The following is a description of a gene set: from publication Setlur SR, Mertz KD, Hoshida Y, Demichelis F, Lupien M, Perner S, Sboner A, Pawitan Y, Andrén O, Johnson LA, Tang J, Adami HO, Calza S, Chinnaiyan AM, Rhodes D, Tomlins S, Fall K, Mucci LA, Kantoff PW, Stampfer MJ, Andersson SO, Varenhorst E, Johansson JE, Brown M, Golub TR, Rubin MA (PMID 18505969) species: Homo sapiens Human Gene Set: SETLUR_PROSTATE_CANCER_TMPRSS2_ERG_FUSION_UP BACKGROUND: The majority of prostate cancers harbor gene fusions of the 5'-untranslated region of the androgen-regulated transmembrane protease serine 2 (TMPRSS2) promoter with erythroblast transformation-specific transcription factor family members. The common fusion between TMPRESS2 and v-ets erythroblastosis virus E26 oncogene homolog (avian) (ERG) is associated with a more aggressive clinical phenotype, implying the existence of a distinct subclass of prostate cancer defined by this fusion. METHODS: We used complementary DNA-mediated annealing, selection, ligation, and extension to determine the expression profiles of 6144 transcriptionally informative genes in archived biopsy samples from 455 prostate cancer patients in the Swedish Watchful Waiting cohort (1987-1999) and the United States-based Physicians(') Health Study cohort (1983-2003). A gene expression signature for prostate cancers with the TMPRSS2-ERG fusion was determined using partitioning and classification models and used in computational functional analysis. Cell proliferation and TMPRSS2-ERG expression in androgen receptor-negative (NCI-H660) prostate cancer cells after treatment with vehicle or estrogenic compounds were assessed by viability assays and quantitative polymerase chain reaction, respectively. All statistical tests were two-sided. RESULTS: We identified an 87-gene expression signature that distinguishes TMPRSS2-ERG fusion prostate cancer as a discrete molecular entity (area under the curve = 0.80, 95% confidence interval = 0.792 to 0.81; P <.001). Computational analysis suggested that this fusion signature was associated with estrogen receptor (ER) signaling. Viability of NCI-H660 cells decreased after treatment with estrogen (viability normalized to day 0, estrogen vs vehicle at day 8, mean = 2.04 vs 3.40, difference = 1.36, 95% CI = 1.12 to 1.62) or ERbeta agonist (ERbeta agonist vs vehicle at day 8, mean = 1.86 vs 3.40, difference = 1.54, 95% CI = 1.39 to 1.69) but increased after ERalpha agonist treatment (ERalpha agonist vs vehicle at day 8, mean = 4.36 vs 3.40, difference = 0.96, 95% CI = 0.68 to 1.23). Similarly, expression of TMPRSS2-ERG decreased after ERbeta agonist treatment (fold change over internal control, ERbeta agonist vs vehicle at 24 hours, NCI-H660, mean = 0.57- vs 1.0-fold, difference = 0.43-fold, 95% CI = 0.29- to 0.57-fold) and increased after ERalpha agonist treatment (ERalpha agonist vs vehicle at 24 hours, mean = 5.63- vs 1.0-fold, difference = 4.63-fold, 95% CI = 4.34- to 4.92-fold). CONCLUSIONS: TMPRSS2-ERG fusion prostate cancer is a distinct molecular subclass. TMPRSS2-ERG expression is regulated by a novel ER-dependent mechanism. Genes up-regulated in prostate cancer samples bearing the fusion of TMPRSS2 with ERG., and this is the list of marker genes: MAP3K5, PDE9A, KCNN2, THUMPD1, PTPRK, MOK, MLXIP, ALDH18A1, SNRPB2, PSMD13, TFDP1, PGD, TBP, PTK7, RAB30, EIF5, ABCC8, ZNF3 (NCBI Gene Id 7551), LRP1, CDK14, GP1BB, PLA2G7, ECE1, CRISP3, MAP2K5, XRCC5, MTA1, RFX1, NDUFS5, PCDHGB7, SMARCD1, SH3YL1, ARHGAP29 (NCBI Gene Id 9411), MYO6, HDAC1, PEX10, MAP7, KHDRBS3, SAFB, ZMYND8, ASAP2, KLC1, UBE2G1, TLE1, ERG, TWIST1, COL9A2, PRKAR1B, AMPD3, UGDH, OCLN, TPP2, SIPA1L1, SEPTIN9, NCOA1, RPP38, SUSD6, CADPS, DBN1, RGS10, GHR, EIF4G3, BMPR1B, BAG5, ARHGDIB, CACNA1D, CPSF6